The following is a description of a gene set: Human Gene Set: DURANTE_ADULT_OLFACTORY_NEUROEPITHELIUM_OLFACTORY_HORIZONTAL_BASAL_CELLS from publication Durante MA, Kurtenbach S, Sargi ZB, Harbour JW, Choi R, Kurtenbach S, Goss GM, Matsunami H, Goldstein BJ (PMID 32066986) species: Homo sapiens, and this is the list of marker genes: MEG3, KRT5, CTSV, TSC22D1 (NCBI Gene Id 8848), F3, AQP3, KRT15, KRT17, IGFBP5, SPINK5, MT1X, BCAM, DST, BASP1, S100A2, MYC, SOX2, NPPC, CXCL14